The following is a description of a gene set: An anomalous response to the corticotropin releasing hormone (CRH) stimulation test. Normally,CRH is released by the hypothalamus to induce adrenocorticotropic hormone (ACTH) release by the anterior pituitary. In the stimulation test, CRH is administered intravenously and ACTH and cortisol are measured at intervals. Human Gene Set: HP_ABNORMAL_RESPONSE_TO_CORTICOTROPIN_RELEASING_HORMONE_STIMULATION_TEST studied in species Homo sapiens Abnormal response to corticotropin releasing hormone stimulation test, and this is the list of marker genes: AAAS, TRAPPC11 (NCBI Gene Id 60684), ARMC5, GMPPA, KDM1A, GNAS, HSD3B2